The following is a description of a gene set: studied in species Homo sapiens Genes discriminating TP53 status across various genotoxic stress agents. Human Gene Set: AMUNDSON_DNA_DAMAGE_RESPONSE_TP53 Gene expression responses of human cell lines exposed to a diverse set of stress agents were compared by cDNA microarray hybridization. The B-lymphoblastoid cell line TK6 (p53 wild-type) and its p53-null derivative, NH32, were treated in parallel to facilitate investigation of p53-dependent responses. RNA was extracted 4 h after the beginning of treatment when no notable decrease in cell viability was evident in the cultures. Gene expression signatures were defined that discriminated between four broad general mechanisms of stress agents: Non-DNA-damaging stresses (heat shock, osmotic shock, and 12-O-tetradecanoylphorbol 13-acetate), agents causing mainly oxidative stress (arsenite and hydrogen peroxide), ionizing radiations (neutron and gamma-ray exposures), and other DNA-damaging agents (ultraviolet radiation, methyl methanesulfonate, adriamycin, camptothecin, and cis-Platinum(II)diammine dichloride (cisplatin)). Within this data set, non-DNA-damaging stresses could be discriminated from all DNA-damaging stresses, and profiles for individual agents were also defined. While DNA-damaging stresses showed a strong p53-dependent element in their responses, no discernible p53-dependent responses were triggered by the non-DNA-damaging stresses. A set of genes did exhibit a robust p53-dependent pattern of induction in response to all nine DNA-damaging agents, however. from publication Amundson SA, Do KT, Vinikoor L, Koch-Paiz CA, Bittner ML, Trent JM, Meltzer P, Fornace AJ Jr (PMID 15824734), and this is the list of marker genes: CDKN1A, ST14, BTG2, PHLDA3, TRIM22, CTSD, TNFSF9, MDM2, ADGRB3, CCNG1, LIF, DDB2 (damage specific DNA binding protein 2), PLXNB2, BTG1, PPM1D (NCBI Gene Id 8493), XPC